The following is a description of a gene set: studied in species Homo sapiens A proteinaceous scaffold found between homologous chromosomes during meiosis. Human Gene Set: GOCC_SYNAPTONEMAL_STRUCTURE, and this is the list of marker genes: MLH3, SYCP2, BLM, TEX11, PLK1, CCNB1IP1, BRCA1, SYCP3, RAD51, MSH4, KASH5, SYCE1L, C14orf39 (NCBI Gene Id 317761), HORMAD1, MEI4, INCENP, SMC3, TEX12, RPA1, FAM9C, SYCE2, DMC1, SMC1B, SYCP1, HORMAD2, FAM9B, FKBP6, RNF212B, SYN1, FAM9A, STAG3, HSPA2, SYCE1 (synaptonemal complex central element protein 1), REC8, BRCA2, RNF212, P3H4, SYCP2L, SYCE3, UBE2I, MLH1